The following is a description of a gene set: Human Gene Set: chr7p21 species: Homo sapiens, and this is the list of marker genes: SCIN, COL28A1, RPL6P21, RPA3, ITGB8-AS1, ENSG00000225606, GIRGL, MGC4859, RAD17P1, LINC02587 (NCBI Gene Id 101927524), RPL23P8, LINC03016, SOSTDC1, BZW2, GTF3AP5, TMEM106B, RNU6-534P, GLCCI1, RBMX2P4, ITGB8, HDAC9-AS1, CRPPA-AS1, LINC02889, ENSG00000200753, AGMO, TWIST1, MRM3P2, AGR2, PHF14, ENSG00000234710, PRPS1L1, ENSG00000199470, RN7SKP266, GAPDHP68, CCNB2P1, BRWD1P3, HSPA8P8, MIOS, VWDE, ICA1, SNX13, ENSG00000237773, RPL21P75, ENSG00000212422, NXPH1, RPL36AP26, RPL36AP29, ENSG00000272537, ETV1, ENSG00000237070, TAS2R2, LRRC72, MACC1-AS1, POLR1F, LINC01162, FERD3L, RPS26P30, ENSG00000243004, ABCB5, UMAD1, TSPAN13, AHR, SP8, CRPPA, AGR3, ENSG00000226097, NDUFA4, GLCCI1-DT (NCBI Gene Id 100505921), THRAP3P3, DGKB, ARL4A, MIR3146, TMEM196, MACC1, ENSG00000197320, MEOX2, PER3P1, EEF1A1P26, RN7SKP228, SNORA63, MIOS-DT, NPM1P13, NPM1P11, THSD7A, C7orf78, EEF1A1P27, SSBL5P, MIR1302-6, HDAC9, RPL23AP52, ICA1-AS1, LINC02888, ANKMY2